Given this list of marker genes St3gal3, St6galnac6, B4galnt2, Fut2, Fut4, Fut9, B3galt4, St3gal4, B3galt5, B3galt2 (NCBI Gene Id 26878), here is a description of the gene set: part of: Blood group systems biosynthesis This event has been computationally inferred from an event that has been demonstrated in another species.<p>The inference is based on the homology mapping from PANTHER. Briefly, reactions for which all involved PhysicalEntities (in input, output and catalyst) have a mapped orthologue/paralogue (for complexes at least 75% of components must have a mapping) are inferred to the other species. species: Mus musculus electronically inferred by orthology from the curated human pathway Reactome Pathway: Lewis blood group biosynthesis